Given this list of marker genes FCGRT, GOLIM4, VKORC1, ANGPTL4, PRNP, PLCD1, RRM2B, RECK, ANTXR2, SEMA4F, FHIT, CD55, CTSW, ECI1, RNASE4, IL10RB, EOMES, LDAF1, HCFC1R1, RPGR, POU6F1, MAPK12, USP48, SOS2, VRK1, CYP4V2, PRSS12, BAG3, TMEM141, LPIN1, PCGF2, PTPN22, CHPT1, F2R, PLEKHA5, NCKAP1, PRKCZ, PROS1, GPC1, GK, PDE8A, SORBS1, RASA4B, CIPC, KCTD12, PALD1, RNF138, ZMAT3, ABCB1, TRAF1, RRAS, MCOLN2, DOCK9, NR1D2, SLC2A1, CD160, IFNAR2, ANKH, IL15RA, AQP9, CHCHD7 (coiled-coil-helix-coiled-coil-helix domain containing 7), TIRAP, PRKCE, IL10RA, here is a description of the gene set: Human Gene Set: GOLDRATH_IMMUNE_MEMORY studied in species Mus musculus 'Memory genes' expressed uniquely in CD8+ memory T lymphocytes (compared with effector or naive cells) from publication Goldrath AW, Luckey CJ, Park R, Benoist C, Mathis D (PMID 15548615) Naive T cells proliferate independently of cognate antigen when introduced into lymphopenic hosts. Lymphopenia-induced proliferation depends on low-affinity MHC/self-peptide complexes and on IL-7. To elucidate the intracellular signals mediating this proliferation, we analyzed changes in gene expression in naive CD8+ T cells at different times after their transfer into a lymphopenic environment. The genes induced in response to lymphopenia were largely an attenuated subset of those turned up by full antigenic stimulation, including genes related to cell cycling, whereas excluding genes specifically associated with effector activity. After the initial phase of proliferation in an empty compartment, the naive T cells adopted a stable pattern of gene expression similar to that of antigen-experienced memory cells. Thus, T cells proliferating in lymphopenic hosts do not exhibit a unique gene-expression profile, instead relying on traditional signals for this antigen-independent proliferation; this process ultimately results in differentiation to authentic memory cells.